The following is a description of a gene set: species: Homo sapiens Genes down-regulated in endothelial cells: untreated versus IFNG and B. burgdoferi. from publication Dame TM, Orenzoff BL, Palmer LE, Furie MB (PMID 17202382) Human Gene Set: GSE6092_UNSTIM_VS_IFNG_STIM_AND_B_BURGDORFERI_INF_ENDOTHELIAL_CELL_DN Borrelia burgdorferi, the agent of Lyme disease, promotes pro-inflammatory changes in endothelium that lead to the recruitment of leukocytes. The host immune response to infection results in increased levels of IFN-gamma in the serum and lesions of Lyme disease patients that correlate with greater severity of disease. Therefore, the effect of IFN-gamma on the gene expression profile of primary human endothelial cells exposed to B. burgdorferi was determined. B. burgdorferi and IFN-gamma synergistically augmented the expression of genes, seven of which encode chemokines. Six of these (CCL7, CCL8, CX3CL1, CXCL9, CXCL10, and CXCL11) attract T lymphocytes, and one (CXCL2) is specific for neutrophils. Synergistic production of the attractants for T cells was confirmed at the protein level. IL-1beta, TNF-alpha, and LPS also cooperated with IFN-gamma to induce synergistic production of CXCL10 by endothelium, indicating that IFN-gamma potentiates inflammation in concert with a variety of mediators. An in vitro model of the blood vessel wall revealed that an increased number of human T lymphocytes traversed endothelium exposed to B. burgdorferi and IFN-gamma, as compared to unstimulated endothelial monolayers. In contrast, addition of IFN-gamma diminished the migration of neutrophils across B. burgdorferi-activated endothelium. IFN-gamma thus alters gene expression by endothelium exposed to B. burgdorferi in a manner that promotes recruitment of T cells and suppresses that of neutrophils. This modulation may facilitate the development of chronic inflammatory lesions in Lyme disease., and this is the list of marker genes: LRRCC1, SEPTIN3, SRRM4, C4orf33, PTF1A, OPN1SW, DLG3, FSHB, ERLIN1, ADAMTSL2, SCN10A, C5orf52, TRIM54, PLEKHA6, MAJIN, DHDH, MYH11, PHOSPHO1, NAV1, CARMIL3, TMTC2, RPL3L, SMYD1, ADARB1, LMO1, RP1, PRPS1L1, RPL31, RNASE10, DPYS, RALGDS, SPHKAP, VPS37A, TAT, SPMIP4, RGS7, SLC23A1, LRP3, DNPH1, SIM2, MARK4, MIB1, MYO9A, PER3, TRIM3, MTURN, PDCD6IP, CNTN2, ZBTB39, THBD, FAM222A, LDAF1, DNAAF6, CST5, TFAP2C, PSCA, PAXX, IZUMO1, PLPPR2 (phospholipid phosphatase related 2), SCP2D1, KIF26A, MTCL2, RXRA, LAPTM4B, BEND7, CABYR (NCBI Gene Id 85304), GSTM2, C2, ANKRD22, TIAM2, NPY5R, SORCS1, PPP1R3C, STXBP6, FAM131B, RDH16, SLA2 (NCBI Gene Id 84174), GPR137, NOTCH4, PRPH, ZFP41, PIEZO2, ENG, ARRDC1, TMEM183A (NCBI Gene Id 92703), RPL37, MTMR10, KCP, CC2D2B, PDPN, CLEC2L, TGFA, PRDM6, SCX, ADAMTSL4, H3C14, GPR75, RBP2, SLC36A2, RABL6, PCYOX1L, CLDN19, HMG20B, LINC00612, SFI1, ABCB8, JPH2 (NCBI Gene Id 57362), SDCBP2 (NCBI Gene Id 27111), CHRNE, STARD10 (StAR related lipid transfer domain containing 10), H2AC25, CXCL2, APBA1, TEX13A, DHX38, INCA1 (inhibitor of CDK, cyclin A1 interacting protein 1), CNKSR1 (NCBI Gene Id 10256), RBM14, SOBP, CRISP2 (NCBI Gene Id 7180), PRODH, MARCO, APOA2, OTP, VAT1L, SOX3, NGF, WDR38, PRR5, FRAT1, CDX4, FGF21, YIF1B, GABRE, CDHR5, CRYBB1, CD163, ZDHHC22, FBN1, GLB1L2, TECTA, ECEL1, CABP7, ITGB1BP1, PCSK1N, TFR2 (transferrin receptor 2), RCN3, NAPEPLD, TPTE, SPOCK2, SLC16A8, NETO1, SLURP1, DNM1, TCF15, GAS6, GAA, PHYHIPL, TMEFF2, NECAB2, PEG10, CCL11, SMPD2, GJB4, KIF1A, ZNF354B, KRT75, CLIP3, GJB3, HOXA11, GIP, CEP85, LRPPRC, CHRNB1, CBX8, INHBE (inhibin subunit beta E), FRMPD1, OR51E1, FGF18 (NCBI Gene Id 8817), LYZL4, SLC2A5, TRIML1, NTN4, DES, ARHGAP8, PADI3, CHRDL1, SLCO2A1, THSD7B, KLHL35, LRRC17, C14orf39, SPATS1, UBN2, PDE1C, NUTM1, OLFM2, HNF4G, STC2 (NCBI Gene Id 8614), OVCA2